Given this list of marker genes Mtss1, Inava, Dlg1, Lypd10, Prickle1, C1ql1, Dsc1, Prtn3, Appl1, Camsap3, Rimbp2, Plxna4, Dlg2, Cntnap2 (contactin associated protein-like 2), Cldn3, F2rl1, Afdn, Cbln2, Nrxn1, Shank3, Pclo, Rab3a, Sema3a, Whrn, Shank1, Bsn, Erc2, Fermt2, Tjp1, Ophn1, Sdf4, Grn, Mpz, Ctbp2, Kirrel1, Kifc3, Plekha7, Syngap1, Cldn1, Csmd2, Prickle2, Adgrl3, L1cam, Rims2, Arf6, Adgrb3, Rapsn, Mpp2, Cntnap1, Lypd11, Epb41l3, Rims1, Pkp1, Cd177, Cbln3, Cbln1, Pard6a (NCBI Gene Id 78389), Shroom2, F2r, Sort1, Nlgn1, Cadm1, Dgkz, Itgb1, Itgb3, Erc1, Hspa8, Csf1r, Pkp2 (plakophilin 2), here is a description of the gene set: The organization process that preserves a cell junction in a stable functional or structural state. A cell junction is a specialized region of connection between two cells or between a cell and the extracellular matrix. Mouse Gene Set: GOBP_CELL_JUNCTION_MAINTENANCE species: Mus musculus